Given this list of marker genes Nr4a3, Ipo13, Ncor2, Fkbp4, Stat3, Nr4a1, Pias2, Cebpb, Psmc3ip, Ep300, Stat5b, Smad3, Ncoa2, Nrip1, Ncoa6, Flt3, Nr4a2, Tacc1, Ets2, Ywhah, here is a description of the gene set: studied in species Mus musculus Binding to a nuclear glucocorticoid receptor. Mouse Gene Set: GOMF_NUCLEAR_GLUCOCORTICOID_RECEPTOR_BINDING